The following is a description of a gene set: species: Homo sapiens Human Gene Set: ZMYM2_TARGET_GENES from publication Yevshin I, Sharipov R, Kolmykov S, Kondrakhin Y, Kolpakov F (PMID 30445619) Genes containing one or more binding sites for (ZMYM2) in their promoter regions (TSS -1000,+100 bp) as identified by GTRD version 20.06 ChIP-seq harmonization., and this is the list of marker genes: RPL6, CHMP6, EEF1D, RFX1, CALM3, TMED8, WRNIP1, TJP3, BASP1-AS1, MIDN, PPIA, PCGF3, CENPN, DCUN1D2, TGIF1, CASTOR1, H3C9P, MLLT1, TIAM1, RPS24P18, RAC3, PRUNE1, RHEB, RPF2, SAE1 (NCBI Gene Id 51502), AHCY, KCNIP2-AS1, STK35, RPS14, RPS6, SMARCD2, WDR76, ADRM1, MTA2, MIR34AHG, NCAM2, EIF4G3, LFNG, MYO9B, TIAM1-AS1, TDRD7, FBXW5, TIGD5, PDE4C (phosphodiesterase 4C), CREBBP, NLRP1, AIP, DOT1L (DOT1 like histone lysine methyltransferase), SKI, BASP1, MINDY1, CSRP1, CDH3, PPP1R14B-AS1, DAP3, LRRC27, SAMD15, ADPRHL1, BRWD1, TMCO3, STEAP1B, RIC1, PFAS, FAF2, PPP1R13L, CDC25B, SERINC2, TPM4, RPL28, MAF1, RN7SL3, CDYL, CDYL-AS1, GDF15, ZNHIT2, AP2A2, PPP5D1P, PIK3R2, C8G, TCTN3, PBX1 (PBX homeobox 1), CMC2, GET4, PDE4A, ICMT, POLR1G, SNORA13, HAUS8, NATD1, GABARAPL1, ARGLU1, TTLL1, OGA, PPIB, NEMF, GALNT10 (NCBI Gene Id 79615), SHARPIN, RCOR2, MPST, PPP4C, C1QTNF6, RAC1, DDHD2, HIBADH, EPB41L4A-AS1, MCC, TST (NCBI Gene Id 96794), BCAR1, RBFOX2, TBC1D31, PPP1R14B (protein phosphatase 1 regulatory inhibitor subunit 14B), JAK2, GAMT, RNU6-1, YY1AP1, DAP (NCBI Gene Id 1611), SMU1, NR6A1, ZC3H4 (zinc finger CCCH-type containing 4), BRAP, PPIC, ERCC4, DAP-DT, NLRX1, MARK2, CSRP1-AS1, ICMT-DT, VEPH1, PRDX2, RNF19A (ring finger protein 19A, RBR E3 ubiquitin protein ligase)